The following is a description of a gene set: Genes up-regulated in CD8 T cells after immunization: day 3 versus day 6. Much is known concerning the cellular and molecular basis for CD8+ T memory immune responses. Nevertheless, conditions that selectively support memory generation have remained elusive. Here we show that an immunization regimen that delivers TCR signals through a defined antigenic peptide, inflammatory signals through LPS, and growth and differentiation signals through the IL-2R initially favors antigen-specific CD8+ T cells to rapidly and substantially develop into tissue-residing T effector-memory cells by TCR transgenic OVA-specific OT-I CD8+ T cells. Amplified CD8+ T memory development depends upon a critical frequency of antigen-specific T cells and direct responsiveness to IL-2. A homologous prime-boost immunization protocol with transiently enhanced IL-2R signaling in normal mice led to persistent polyclonal antigen-specific CD8+ T cells that supported protective immunity to Listeria monocytogenes. These results identify a general approach for amplified T memory development that may be useful to optimize vaccines aimed at generating robust cell-mediated immunity. Gene expression analysis was performed for OT-I T cells on day 3 and day 5 after activation with ovalbumin and LPS in vivo with and without treatment with IL-2 using an agonists IL-2/anti-IL-2 complexes (IL2/Jes-6.1) Human Gene Set: GSE39110_DAY3_VS_DAY6_POST_IMMUNIZATION_CD8_TCELL_UP species: Homo sapiens from publication Castro I, Dee MJ, Malek TR (PMID 23018461), and this is the list of marker genes: RPS5, ZHX2, GPR68, UQCC5, CEBPZ, TCF7, TAGAP, HEXA (hexosaminidase subunit alpha), RPL19, RPS11, ZER1, IGSF9B, PCMTD1, MZF1, MMP23B, RPL12, TBC1D4, ATXN2, DYM, ZFR2, LTO1, NMNAT3, MYBBP1A, EIF5, DDX5, NHSL2, DNAJB2, SLC31A2, ADI1, MCCC2, KIAA0930, CPA2, PNPLA7, POU6F1, GJD4, MPPE1, PADI2, KLK8, KLHL6, GZMM, RPL17, RMDN1, SPTSSA, SLC9A8, FOXP1, BTG1, BCL2, PRSS12, SAYSD1, ZSCAN26, CHD3, BTG2 (BTG anti-proliferation factor 2), HINT2, KCTD2, UBN2, SEMA4F, RABAC1, DDX18 (DEAD-box helicase 18), DBNDD2, TRAF1, RRM2B, SLFN5, SELENOP, CTNS, RPL38, PRMT3, CCL22, ETFBKMT, SORL1, FILIP1L, C8orf82, GALNT10 (NCBI Gene Id 79615), RRP12, WDR11, CRIM1, ZNF878, TENT5A, PDK1, ALOX12B, IFRD2, VKORC1 (vitamin K epoxide reductase complex subunit 1), PIK3IP1, SUCO, LDLRAP1, PHF21A, CD7, MARVELD1, IQGAP2, AMIGO2 (NCBI Gene Id 347902), CAMSAP2, SERINC4, ACP5, MPND, SNORC, AUH, PCTP, RASGRP1, TENT5C, TXNIP, HRH4, MAPK11, EDARADD, KLRK1, NOP10, ARID4B, PARP8, ABTB3, CDKN1B, NSG2 (NCBI Gene Id 51617), PRMT2, ABI3, BBS2, RPS15A, RAB37, RGS10 (NCBI Gene Id 6001), CCND2, PLEKHM3, NR1D2, RPS7, DNAJC28, GPR183, RPS16, RGS2, MPHOSPH10, KLRD1, ZFP36L2, RBCK1 (NCBI Gene Id 10616), SH2B3, TECPR1, SH2D4B, EYA2, ARHGAP5, MAU2, STX4, LATS2, CYLD, IFIT1, RPL14, TNFSF14, FAM114A1, FBXO17, KCNJ8, ARL4C, VPS28, SNHG17, NT5E, LAT, UTP20, IMPACT, UTP25, PARP16, TRMT112, WASL, KLF2, PILRB, SLC9A9, ACAT1, C22orf39 (chromosome 22 open reading frame 39), HSD17B11, VIPR1, RPL37A, FKBP3, OTUD1, ENTREP3, NME2, CDKN2A, CARD6, QPCT, TMEM63A, ATXN7L3B, ACADSB, GID4, AP3M2, DMRTA1, FAM161A, ACSS1, CLRN3, TDRP (NCBI Gene Id 157695), IER5, RFLNB (refilin B), TLR1, PDCD4, SPEF2, L3MBTL3, EVL, SNHG7, IER3, EIF4A2, IL7R, LYPD6B, PKP4, ITGB3, WWP1, HVCN1, GDI1, ST3GAL6, HSPA9, B4GALT1, DIPK1A, ALG1